The following is a description of a gene set: from publication Kaji T, Ishige A, Hikida M, Taka J, Hijikata A, Kubo M, Nagashima T, Takahashi Y, Kurosaki T, Okada M, Ohara O, Rajewsky K, Takemori T (PMID 23027924) species: Homo sapiens Genes up-regulated in day 7 memory B cells versus day 40 germinal center B cells. To obtain insight into the genetic basis of the increase of functional activity of memory B cells over time, we compared the gene expression profiles of day 7 and day 40 NP-specific/IgG1 memory B cells, GC B cells and plasma cells in immunized WT mice and naïve B cells, before and after activation in vitro. Human Gene Set: GSE11961_MEMORY_BCELL_DAY7_VS_GERMINAL_CENTER_BCELL_DAY40_UP, and this is the list of marker genes: NCEH1, RNF39, CASP12, PGF, MARS1, UBA7, ATP10A, GSTM1, IL25, ATP6V0A4, LRP11, ABTB2, ASB13, DHX8, GAS6, BST2, NAA25, COX10, TMEM229B, GSDMA, TOMM70 (translocase of outer mitochondrial membrane 70), BGN, MOV10, INPP1, ST3GAL6, ERAP1, RMDN2, LRATD2 (NCBI Gene Id 157638), PIGR, FASTKD5, CD86, GBP2, TNFSF10, XKR5, OR11H4, ZNF623, SMOX, GIMAP7, URB2, GNL3, PRDM6, SLC7A5, GPR65 (G protein-coupled receptor 65), CMSS1, NOB1, CHMP5, DTX4, ZIM3, LRP12, SNHG6, VGF, ACOD1, HSPH1, CNOT6L, TMEM192, TREML2, MUC13, JAK3, TMEM53, ZNF750, FKBPL, CD300LB, ZNHIT6, CXCL10, URB1, CINP, CAMK2B, ISG20L2, WARS1, CHCHD4, KLK4, KHDC3L, MYO19, ASS1 (argininosuccinate synthase 1), PAFAH1B2, EPSTI1, SPOCK3, NAMPT, CFLAR, RASA4, GUCA1B, FBXO44, PDXP, PCID2, HOOK2, CLPB (ClpB family mitochondrial disaggregase), GPR27, PPP1R21, NAA20, CHST13, ITPK1, TCP11, INO80, PARP3, MRPL38, KRT72, ZNF516, CCHCR1 (coiled-coil alpha-helical rod protein 1), DNAH2, TRAFD1, DPP6, DEK, GNPTAB, STK31, B4GALT5, SH3BP2 (NCBI Gene Id 91018), CMTR2, EBP, PTPN23 (NCBI Gene Id 96248), PFKFB3, SORBS3, GBP6, ORM1, EIF3J, MYCBP2, WDR43, RESP18, POU3F2, MYH11 (myosin heavy chain 11), IFIT1B, P2RY14, MED11, INKA1, MINPP1, ANKFY1, DNAL1, PNPT1, ALG8, SFXN2, TOR1AIP2, ZC3HAV1, FOXQ1, MGAT4EP, GART, ZNG1B, PNO1, SETDB2, USPL1, RRP15, ZNF444, ADAR, GEM, SPRED2, CISD1, APOBEC1, PSD2, RABEPK, NHP2, FBLN7, PRSS44P, IL12RB1, DNAJB6, TNXB, PCLO, RBM19, MLKL, TRO, ERGIC1, LYAR (Ly1 antibody reactive), PMEPA1, XAF1, ZFP90, MRPL22, SPARC, STIP1, SEMA4D, IRF1, TCOF1, UBAP1, BIRC2, IFRD1, PPP1R3D (NCBI Gene Id 5509), NKX2-3, CWC22, PROCA1, KAT2A (NCBI Gene Id 2648), SLC30A2, METTL13, NECTIN4, ANKRD1, RSL24D1, GPM6B, GABRD, UNC13C, COL27A1, MYC, TRIM5, AXL, CADM2, CUBN, ST13, ZNF628, OSTC, GEMIN6, NUDT6, SMCHD1, MRPS6, XPO1, MIF, GBP7